The following is a description of a gene set: Genes containing one or more binding sites for (F10) in their promoter regions (TSS -1000,+100 bp) as identified by GTRD version 20.06 ChIP-seq harmonization. Human Gene Set: F10_TARGET_GENES studied in species Homo sapiens from publication Yevshin I, Sharipov R, Kolmykov S, Kondrakhin Y, Kolpakov F (PMID 30445619), and this is the list of marker genes: PLAAT1, SEMG1, TCIM, ZC3H6, PKIB, IST1, NRBP1, PLCH1, C12orf57, SDC2, MTERF4, SLC17A6-DT (SLC17A6 divergent transcript), VPS33A, CREB3L2, KCTD6, ENSG00000253660, SCHIP1, RPL21P112, ZFHX3, RNU7-27P, EPHA4, CENPA, UBE2Z, RNU7-1, EHBP1, RBBP5, ANKRD6, NCAM2, TIA1, SOX5, RNVU1-15, TRDMT1, ADAT2, ADGRA2, PGAM1P5 (NCBI Gene Id 100508806), RPL31P24, COX6A1, DPH6-DT, PDE4B, MIR302A, CDK6, RPL23AP53, SSBP2 (NCBI Gene Id 51492), RGMB, AFP, JPX, RBMS1 (RNA binding motif single stranded interacting protein 1), PARD3, KLF7-IT1, ZW10, CXXC4, FHOD3, DMD, TRPC6P9, AKT1, INSYN2B, SLC10A2, ABCC9, MIR302C, GBA1, NEDD9, FAM120B, KLHL32, TTC7B-AS1, MIR302CHG, LRRN1, CCN2, OGT, AJUBA-DT, PEX3, AKAP10, MYO6, SGMS1, NCAM1, HSPD1P9, LINC01650, JMJD1C, RNU5B-1, GABBR1, TAPT1, LINC02730, ELOVL6, PRTG (protogenin), DARS1-AS1, SEPHS1, ATP6V0A1, CACNB2, CP, YWHAE, DTHD1, HMGCS1, SPART, NEDD4L, MAP4K3, LRBA, SPHK1, PHLDB2, PRSS12, NFAT5, MAML2, GPA33, ZNF341, COL3A1, RNU4-8P, LINC01852, SUMF1, TENM2, NBN, TRAM1, ARHGAP24, NR2F6, EYA1, NRM, RAPGEF2, POU3F2, LEF1-AS1, ACTR1B, ARHGEF12, VPS41, TNKS, PBX3, RGS12, DUSP4, LINC02960, CCN1, LINC01069, GPX8, RBPMS, RNU4-91P, EGLN3, UBE2E3, ENSG00000240497, ADAM7-AS1, STK36, ENSG00000229425, DKK2, PDGFC, TNFRSF10B, RNF150, GTPBP8, SLC29A1, APPL2, MIR1538, SETBP1, MOV10, KCTD1, TCAIM, CAPS2, TRAPPC9, ZNF280D, NRCAM, STAT3, MEF2A, NFXL1, TCF12, SH3BGRL, AGFG1, PHIP, SMARCA2, TENM3, LINC01186, MIR302D, RBM28, GSTA4, THAP10, CYFIP2, MARCKS, SPATA13, USP44, RBMS3-AS3, KCND3-AS1, MIR99AHG, KANSL3, INTS5, H2AC25, ANKRD28, MYO1B, ZNF579, ARHGAP5, LTBP1, C10orf67, TMEM230, DNAJB4, PTPRZ1, CDK5RAP1, C2orf42, AGAP1, FRMD4B, KLHL4, QKI, BMPR1B, TLR3, CXCR4, B4GALT4, VSTM2L, CDK12, LINC01603, ILF2, ZNF518A, PPP1CB (NCBI Gene Id 5500), GRIA1, TRIM7-AS2, LINC03116, KIAA0232, PKN2, PTGES3P3, USP30, ACACA, FN1-DT, IGF1R, SALL2, SMARCD2, IRAIN, GLUL, RHOBTB3, HMGN5, ZNF57, DIAPH1, GNAL, FBXO11, ATP2C1, LRRC49, ASF1A, CTNND2, DLD, ANKRD40, RNU1-23P, NABP1, CRACD, ENSG00000231119, TXLNB, LARP7, DHX16, AAR2, SLF1, MIR7515HG, ENSG00000247416, INTS2, DIPK1B, UBE2E3-DT, MLEC, NEFM, FGF2 (NCBI Gene Id 2247), MAP1B, EML1, LINC02280 (long intergenic non-protein coding RNA 2280), STAT1, MIR3681HG, SRFBP1, RNU11 (RNA, U11 small nuclear), GRM3, ZNF821, THG1L, VTRNA1-3, CSRNP3, CAHM, LYSMD3, SLC44A1, RNU6-263P, MPDZ, APELA, GTF3C3, MMP10, TIAM2, ITGB8, LNCRNA-IUR, OLA1, LACTB2-AS1, CDH2, ENSG00000228365, CSTPP1, NR2F1, AASS, MDGA2, PPP3R1, STARD4, ATXN7L3B, DHX32, MAP2, EDEM2, ENSG00000233230, PCDH10-DT, AJUBA, MTF2, NAMPT, SYNCRIP (NCBI Gene Id 10492), UACA, COMMD2, TMEM71